Given this list of marker genes Dhx36, Il1b, Tlr4, Nlrx1, Kit, Trim55, Spon2, Ube2j1, Sirt1, Mapkapk2, Gorasp2, Ash1l, Mif (NCBI Gene Id 17319), Sucnr1, Fcer1g, Twist1, Panx1, Atg9a, Psen2, Tlr2, Casp4, Mavs, Plcg2, H2-M3, P2rx7, Rtn4, Tgfb3 (NCBI Gene Id 21809), Laptm5, Psg22, Wnt5a, Litaf, Rigi, Tgfb1, Rabgef1, Mir324 (NCBI Gene Id 723896), Tirap (toll-interleukin 1 receptor (TIR) domain-containing adaptor protein), Hmox1, Nlrp3, Casp1, Cd36, Pycard, Irak3, Gprc5b, Cd74 (CD74 antigen (invariant polypeptide of major histocompatibility complex, class II antigen-associated)), Bcl6, Card9, Tgfb2, Tlr7, Axl (AXL receptor tyrosine kinase), Ifng, Hspa12a, Myd88, Sema7a, Ddx1, Nr4a3, Ticam1, Gas6, Nod2, Acp5, Nod1, Twist2, Ripk2, Fcer1a, Rasgrp1, Epx (NCBI Gene Id 13861), Cuedc2, Syk, Tlr3, Prg2, Ddx21, here is a description of the gene set: Mouse Gene Set: GOBP_MYELOID_LEUKOCYTE_CYTOKINE_PRODUCTION Any process that contributes to cytokine production by a myeloid cell. species: Mus musculus